The following is a description of a gene set: species: Homo sapiens Any process that results in a change in state or activity of a cell (in terms of movement, secretion, enzyme production, gene expression, etc.) as a result of a UV-A radiation stimulus. UV-A radiation (UV-A light) spans the wavelengths 315 to 400 nm. Human Gene Set: GOBP_CELLULAR_RESPONSE_TO_UV_A, and this is the list of marker genes: TIMP1, OPN5 (opsin 5), MME, MMP1, MMP2, MMP9, OPN3, OPN1SW, PPID, CERS1, MMP3